Given this list of marker genes TUBB2B, KLC1, TUBA1A (tubulin alpha 1a), TUBB2A, TUBB, TUBA3D, TUBB6, TUBB4B, KLC4, KIF5C, KIF5B, TUBB1, MAPK10, TUBB4A, TUBA4A, TUBB3 (tubulin beta 3 class III), TUBA8, TUBA3E, KIF5A, TUBA1C, HTT, TUBA1B, KLC3, KLC2, TUBA3C, TUBB8, here is a description of the gene set: species: Homo sapiens Human Gene Set: KEGG_MEDICUS_VARIANT_MUTATION_CAUSED_ABERRANT_HTT_TO_ANTEROGRADE_AXONAL_TRANSPORT Mutation-caused aberrant Htt to anterograde axonal transport. Pathway ID: N00979. Pathway type: Variant. Pathway class: nt06461 Huntington disease. Pathway Definition from KEGG: HTT* -> JNK3 -| (KIF5+KLC) == (TUBA+TUBB)